Given this list of marker genes PCSK1N, BRWD3, EED, ZNF319, BLOC1S6, KLHL9, AGR3, KIF3A, POLD1, CKMT1B, CCDC117, PIGN, ECT2, MRRF, PLCZ1, ZBTB48, MGST1, MTHFS, SIRT3, MTFMT, BTK, RITA1, RPP21, RAB13, RFC1, UCHL3, NDUFS2, ASB4, MRPL43, NDUFB10, GABPA, FMC1, GPR65, IFNB1, JKAMP, RPS11, PDPK1, MOG, HADHB, XPA, SLURP1, SAAL1, PMEL, SLC25A28, ZNF600, ACAT2, FLYWCH2, UQCRB, SGPP1 (sphingosine-1-phosphate phosphatase 1), FBXO43, ANAPC5, PAK3, COMMD5, DBR1, PTCD2, MINDY1, EPRS1, LPGAT1 (lysophosphatidylglycerol acyltransferase 1), ZW10, BST1, SEPTIN10 (NCBI Gene Id 151011), GPR89B, RBM10, ANGEL1, CHAC2, ORC6, C6orf120, TRAPPC1 (NCBI Gene Id 58485), TSR3, EBP, DUT, PELI1, CDKL2, PAPPA, TMEM134, DIAPH3, AKR7A2, NT5C2, ACAD8, CPTP, EID1, MPHOSPH8, KCNJ9, GMPPA, PRDX2, RMDN3, SCAND1, OR51B4, POLD2, SPAG7, GOLPH3L, ASPA, NSDHL, TSEN34, AKR1B1, DPH2, LAMTOR2, ZNF688, MRPL19, NDC1, VAMP4, NSMCE3, OTUD6B, SERP1 (stress associated endoplasmic reticulum protein 1), MAZ, PSMA5, SPEG, VCF1, KLHL20, TWF2, KCNK7, TMCO1, CCT3, YTHDF2 (YTH N6-methyladenosine RNA binding protein F2), SERINC3, PSMF1 (NCBI Gene Id 9491), DR1, CRYBA2, MLLT6, ZNF398, HSPB2, PALS2, CCNE2, RNFT1, SOCS7, MFSD4B, CAP1, FBXL14, FKBP3, PMS2, SBF2, MTERF4, ABHD16A, ARG1, CMKLR1, NQO2, F8, LACTB2, ARL6IP6, BAK1, MED8, FTSJ1, PTGR2, TRAM1, RNF138, SLC4A10, DDX10, SERF2, SEH1L, UBE2L6, MRPL28, ERH, ZNF347, FAM3B, SUGT1, HLA-DOA, HNMT, C1QBP, CCR6, PUM3, SRRD, MRPS31 (mitochondrial ribosomal protein S31), SARNP, LEPROTL1, RAB3A, NDUFB6, TMED3, SLC25A45, CBX3, THTPA, RNF43, ITIH3, BDH1, MAK16 (MAK16 homolog), HIBADH, MRPL51, KAZALD1, ERG28, SH3BGRL, FAM234B, RPS15A, CBLN3, RUVBL1, RBM15, NUDCD2, UQCRC2, CCNQ, COPS6, YJEFN3, ZBTB1, TMEM100, PSAT1, GJB2, GRHPR, MRM1, NAT9, GMPPB, CD164, MFAP1, PITPNM2, here is a description of the gene set: from publication Amit I, Garber M, Chevrier N, Leite AP, Donner Y, Eisenhaure T, Guttman M, Grenier JK, Li W, Zuk O, Schubert LA, Birditt B, Shay T, Goren A, Zhang X, Smith Z, Deering R, McDonald RC, Cabili M, Bernstein BE, Rinn JL, Meissner A, Root DE, Hacohen N, Regev A (PMID 19729616) studied in species Homo sapiens Human Gene Set: GSE17721_LPS_VS_PAM3CSK4_1H_BMDC_UP mouse primary BMDCs were stimulated with tlr ligands and gene expression changes were profiled on Affymetrix arrays Genes up-regulated in comparison of dendritic cells (DC) stimulated with LPS (TLR4 agonist) at 1 h versus DC cells stimulated with Pam3Csk4 (TLR1/2 agonist) at 1 h.